Given this list of marker genes TRAK2 (NCBI Gene Id 66008), GRIK3, STAU1, STAU2, ABHD13, DLG4, KIF5B, RAB17, KIFAP3, HIP1R, KIF5C, LRRK2, BAIAP2, HPCA, CDKL5, WASF1, ZC3H14, SOD1, FLOT2, UHMK1, KIF17, KIFC2, GRIK2, ABHD12, MAP2 (microtubule associated protein 2), MAP2K1 (NCBI Gene Id 5604), KIF3B, KIF5A, here is a description of the gene set: All of the contents of a dendrite, excluding the surrounding plasma membrane. Human Gene Set: GOCC_DENDRITE_CYTOPLASM studied in species Homo sapiens